The following is a description of a gene set: studied in species Homo sapiens Human Gene Set: GOMF_DEOXYRIBONUCLEASE_I_ACTIVITY Catalysis of the endonucleolytic cleavage of DNA to 5'-phosphodinucleotide and 5'-phosphooligonucleotide end products., and this is the list of marker genes: DNASE1L3, DICER1, DNASE1L2, DNASE1, DNASE1L1